Given this list of marker genes PRKAA2, PRKAG1, PRKAB2, PRKAA1 (protein kinase AMP-activated catalytic subunit alpha 1), PRKAG3, PRKAG2, here is a description of the gene set: Catalysis of the reaction: ATP + a protein = ADP + a phosphoprotein. This reaction requires the presence of AMP. Human Gene Set: GOMF_AMP_ACTIVATED_PROTEIN_KINASE_ACTIVITY species: Homo sapiens